Given this list of marker genes Senp3, Otulinl, Usp38 (ubiquitin specific peptidase 38), Alg13, Usp2, Mindy4, Desi2, Otud7b, Usp17lc, Atxn3, Ufsp2, Senp2, Mindy3 (NCBI Gene Id 99325), Usp10, Usp50, Wdr20, Usp36, Usp26, Usp17lb, Semp2l1, Otud1, Usp13, Usp37, Desi1, Zup1, Psmd14, Usp16, Otub2, Usp17la, Usp21, Usp28, Usp22, Tgfb1, Brcc3, Usp19, Eif3h, Usp4, Usp46, Usp33, Usp32, Usp14, Otud4, Usp27x, Usp3, Otud6b, Usp48, Semp2l2a, Hint1, Usp51, Usp45, Josd2, Yod1, Zranb1, Senp8, Uchl4, Usp9y, Zc3h12a, Usp17ld, Wdr20rt, Otud3, Uchl3, Ufsp1, Usp40, Usp24, Uchl1, Mindy2, Otud6a, Otulin, Otud7a, Stambp, Usp20, Tnfaip3, Mindy1, Josd1, Usp8, Usp34, Senp7, Tank, Usp25, Usp39, Usp7, Stambpl1, Usp43, Usp44, Usp11, Usp35, Eif3f, Mindy4b-ps, Vcpip1, Uspl1, Usp53, Usp5, Usp31, Tifab, Usp29, Vcp, Senp6, Wdr48, Semp2l2b, Cops5, Usp30, Senp1, Usp12, Senp5, Cep63, Usp18, Dmwd, Usp54, Usp1, Otud5, Usp49, Bap1, Mysm1, Usp47, Cyld, Uchl5, Otub1, Usp17le, Brcc3dc, Usp9x, Usp42, Usp15, here is a description of the gene set: Mouse Gene Set: GOMF_UBIQUITIN_LIKE_PROTEIN_PEPTIDASE_ACTIVITY An isopeptidase activity that cleaves ubiquitin or ubiquitin-like proteins (ULP; e.g. ATG8, ISG15, NEDD8, SUMO) from target proteins. studied in species Mus musculus